The following is a description of a gene set: This event has been computationally inferred from an event that has been demonstrated in another species.<p>The inference is based on the homology mapping from PANTHER. Briefly, reactions for which all involved PhysicalEntities (in input, output and catalyst) have a mapped orthologue/paralogue (for complexes at least 75% of components must have a mapping) are inferred to the other species. part of: Metabolism of carbohydrates and carbohydrate derivatives electronically inferred by orthology from the curated human pathway Reactome Pathway: Lactose synthesis species: Mus musculus, and this is the list of marker genes: Lalba, Slc2a1